The following is a description of a gene set: studied in species Homo sapiens Human Gene Set: chrYq11, and this is the list of marker genes: TTTY9B, RAB9AP2, TRIM60P8Y, TUBB1P2, USP9YP29, NLGN4Y-AS1, RBMY2UP, OFD1P13Y, FAM8A4P, TRAPPC2P10, RAB9AP3, OFD1P18Y, CDY1, ZNF839P1, XKRYP7, RPS24P1, RNA5SP521, CDY7P, DAZ2, DPPA2P1, ZNF736P11Y, RAB9AP5, TRIM60P5Y, CDY22P, TTTY4B, ZNF886P, USP9YP19, RNU1-41P, ELOCP35, BPY2B, OFD1P9Y, TRAPPC2P8, VCY, SHROOM2P1, MED13P1, SEPTIN14P23, TRAPPC2P5, ELOCP7, USP9YP9, USP9YP5, DUX4L16, ELOCP11, CDY13P, RNU1-48P, USP9YP36, REREP1Y, PPP1R12BP1, DAZ4, XKRY, HSFY1, CDRT15P10, USP9YP7, USP9Y, USP9YP3, USP9YP16, GPM6BP2, CDY19P, CD24P4, RAB9AP1, CYCSP46, RBMY1HP, USP9YP17, MTND1P12, TTTY13, GOLGA6L11P, RNA5SP522, GOLGA2P3Y, USP9YP25, UBE2Q2P5Y, TRAPPC2P4, TPTE2P4, RBMY2CP, FAM224A, USP9YP31, USP9YP2, CDY1B, ELOCP14, USP9YP11, USP9YP32, TTTY17B, RBMY1E, TTTY14, RNA5SP520, ENSG00000288049, OFD1P7Y, PABPC1P5, XKRYP5, ZNF736P12Y, ZNF736P4Y, RN7SL725P, NEFLP1, TUBB1P1, ANKRD36P1, TTTY10, SEPTIN14P22, USP9YP8, USP9YP21, RNU6-255P, RNU1-86P, RBMY1B, CYCSP48, RPS4Y2, ARSLP1, KDM5D, RBMY2BP, OFD1P15Y, EIF1AY, HSFY5P, XGY1, USP9YP14, GOLGA2P2Y, TRAPPC2P9, ENSG00000252689, TTTY25P, KDM5DP1, ARSDP1, TOMM22P1, CDY8P, CDY18P, STSP1, ELOCP5, ACTG1P11, USP9YP28, TSPY23P, ACTG1P2, RNA5SP523, PNPLA4P1, ELOCP36, RCC2P1, USP9YP34, CDY17P, ELOCP26, XKRYP1, ELOCP17, USP9YP12, USP9YP23, RNU1-95P, USP9YP10, OFD1P11Y, CDY15P (NCBI Gene Id 386737), RBMY1A1, RN7SL818P, CDY23P, ELOCP12, OFD1P5Y, TTTY9A, XKRYP2, CDY10P, FAM41AY1, ACTR3BP1, CDY2A, MXRA5Y, RBMY2FP, UBE2Q2P4Y, SURF6P1, CDY20P, ENSG00000235059, CHEK2P1, ANOS2P, OFD1P8Y, RNU1-97P, RN7SL702P, ZNF736P1Y, CDY4P, LINC00265-2P, TTTY4C, RBMY1KP, CDY12P, TSPY14P, VCY1B, USP9YP6 (NCBI Gene Id 387360), SNX18P1Y, HSFY2, RNU1-128P, UTY, SFPQP1, HSFY8P, SLC25A15P1, OFD1P1Y, ELOCP8, ELOCP34, RNU6-1314P, TAB3P1, DNM1P24, TSPY21P, GOLGA6L16P, DNM1P48, CDY14P, FAM224B, BCORP1, CSPG4P4Y (NCBI Gene Id 107987351), CDY2B, TTTY4, BPY2, REREP2Y, TRIM60P10Y, CLUHP1, RBMY2EP, ZNF736P5Y, RAB9AP4, XKRYP4, CSPG4P1Y, RBMY2WP, USP9YP27 (USP9Y pseudogene 27), ARSFP1, ELOCP9, RNU1-107P, RNU6-109P, TMEM167AP1, TXLNGY, DUX4L17, PSMA6P1, USP9YP24, TMSB4Y, CLUHP2, OFD1P4Y, USP9YP30, RBMY2AP, RNU6-184P, NLGN4Y, TTTY3, OFD1P2Y, SLC9B1P1 (solute carrier family 9 member B1 pseudogene 1), CYCSP49, CDY11P, GPM6BP1, DUX4L18, PPP1R12BP2 (NCBI Gene Id 360020), USP9YP18, RBMY2YP, RBMY2TP, TRAPPC2P7, BPY2C, RBMY1D, ANKRD20A6P, USP9YP33, DAZ3, MTCYBP2, HSFY4P, AGKP1, ZNF885P, TSPY22P, TTTY6, TRIM60P9Y, CICP2, ELOCP6, SNORA70 (small nucleolar RNA, H/ACA box 70), TTTY3B, ZNF736P3Y, USP9YP35, USP9YP20, XKRYP3 (XK related, Y-linked pseudogene 3), ZNF736P2Y, XKRYP6, CICP1, CSPG4P2Y, ELOCP16, MED14P1, ELOCP10, TAF9P1, DDX3Y, ASS1P6, OFD1P6Y, USP9YP1, CDY9P, PUDPP1, TTTY5, GAPDHP19, PRORY (PRORY Y-linked lncRNA), CDY6P, CSPG4P3Y, RBMY1J, LINC00265-3P, USP9YP13, RCC2P2, TTTY17C, GYG2P1, CASKP1, OFD1P10Y, RNU1-40P, ELOCP13, TRAPPC2P3, TAF9P2, RBMY1F, ENSG00000236951, FAM41AY2, TRIM60P11Y, DUX4L19, TBL1YP1, CDY5P, RBMY2XP, ELOCP15, OFD1P12Y, USP9YP15, DAZ1, ENSG00000295422, HSFY6P, OFD1P16Y, TTTY17A, RBMY2DP, TTTY6B, HSFY7P, USP9YP26, GAPDHP17